The following is a description of a gene set: part of: Signaling by KIT in disease Many of the described KIT mutations are located in the fifth Ig-like domain, encoded by exon 8 and 9. The fifth Ig-like domain of KIT plays a critical role in stabilizing the receptor dimers formed upon SCF binding, allowing these mutations to support constitutive activation of the receptor Reactome Pathway: Signaling by extracellular domain mutants of KIT species: Homo sapiens, and this is the list of marker genes: KIT